The following is a description of a gene set: A dendrite that emerges near the apical pole of a neuron. In bipolar neurons, apical dendrites are located on the opposite side of the soma from the axon. Human Gene Set: GOCC_APICAL_DENDRITE studied in species Homo sapiens, and this is the list of marker genes: HCN1, MAP1B, OSBP2, SLC17A8, ITSN1, SLC4A10, SEZ6, MYO1D, CPEB3, MAP2 (NCBI Gene Id 4133), NSMF, PTK2B, YKT6, CLU, SLC1A1, FLNA, NEURL1, GSK3A